Given this list of marker genes GNPDA2, PITX2, NAP1L3 (NCBI Gene Id 4675), CEACAM21, AP1S3, WAC, STEAP2, ZDHHC20, CCL2, MND1 (meiotic nuclear divisions 1), ENPP5, TRIM44, GSDME, ATP6V1B2, SH3KBP1 (SH3 domain containing kinase binding protein 1), AKAP17A, ACO1, WLS, RPGR, SRRM2, ZNF780A, MYO5A, LYSMD2, CCT3 (chaperonin containing TCP1 subunit 3), GPRIN3, TSR2, CPSF6, CMBL, BRD8, SLC20A1, ARRDC3, DISP1, MYOCD, PRTG, MARK1, ZNF454, C3AR1, GK, MAPRE2, CHD8, PAK5, SYAP1, TCAF1, LIG3 (NCBI Gene Id 3980), SLCO1A2, STRBP, NR2C2, SETD5, PDK1, LYN, RNF130 (ring finger protein 130), P4HTM, RIF1, CCN1, THOC1, SNHG14, PITRM1, ZNF467, ANKRD29, ID2, MOSPD2, CRYAA, ERICH3, HOXA10, NIPAL1, TRIM9, GMDS, CSGALNACT1, GLB1L, KMT5A, HDAC2, SLC43A3, C1QL3 (complement C1q like 3), ANKRD28, ANK3, EBF1, EID2, OLIG2, ADGRL4, MNDA, RTP4, SMOC2, PRELID2, HLA-B, MATR3, MAU2, THBS2, EMC9, MAPDA, SPDYA, FLT1, WDR33, USP14, ZNF286A, YES1, PLXNA2, EN1, SCRG1, NR3C1, ZMYM2, GATA6, KDM5C, SLBP, GLA, EGR1, SBSPON, DNAJA4, TTC9, CCDC103, ARSJ, RPL15, NCAM1, GDA, KAT7, DYNLT3, CFAP91, KIF24, MAOA, ST3GAL6, QNG1, PDE8A, TGM2, NID1, WDR37, BTBD7, DTNA, S1PR3, WASL, ZNF22, GOT2, MANBA, RP2, PCSK6, PLPP3, P3H2, SORD (sorbitol dehydrogenase), CENPE (centromere protein E), GALNS, FJX1, CNRIP1, JMJD1C, IGFBP7, TNFAIP2, HTRA1, HOXA7, MBTPS2, ARHGAP32, YTHDC2, C12orf42, PACC1, CLSTN1, TUBB2B, VEGFD, PLGRKT, CCL7, CXCL12, JAM2, NAV3, C2CD3, B3GAT1, TRIM2, ANKRD50, ATP7A, RMDN1, SBNO2 (NCBI Gene Id 22904), RGS2, SSX2IP, HUWE1, MYH9, TNFAIP8 (NCBI Gene Id 25816), ZNF518A, CAMK1D, PCDH19, TNRC6A, GJB2, CA5B, WIPF1, AKR1B10, NRP1, TPGS2, SYT12, EMP2, PPM1H, TDRKH, CRYL1, FHDC1, GAS2L3, HBEGF, RBMX, TP53 (tumor protein p53, NCBI Gene Id 7157), LHX9, CD209, APC, RNF138, PFKFB2, PRPF3, DTL, here is a description of the gene set: Up-regulated genes from the set A (Fig. 5a): specific to cells expressing MLL-AF4 fusion protein alone. from publication Gaussmann A, Wenger T, Eberle I, Bursen A, Bracharz S, Herr I, Dingermann T, Marschalek R (PMID 17130830) The reciprocal chromosomal translocation t(4;11) is correlated with infant, childhood, adult and therapy-related high-risk acute leukemia. Here, we investigated the biological effects of MLL.AF4, AF4.MLL or the combination of both reciprocal fusion proteins in a conditional in vitro cell culture model system. Several parameters like cell growth, cell cycling capacity, apoptotic behavior and growth transformation were investigated under physiological and stress conditions. Co-transfected cells displayed the highest resistance against apoptotic triggers, cell cycling capacity and loss-of-contact inhibition. These analyses were complemented by gene expression profiling experiments and specific gene signatures were established for each of the three cell lines. Interestingly, co-transfected cells strongly upregulate the homeobox gene Nanog. In combination with Oct4, the Nanog homeoprotein is steering maintenance of pluripotency and self-renewal in embryonic stem cells. Transcription of Nanog and other stem cell factors, like Oct4 and Bmi1, was verified in biopsy material of t(4;11) patient cells which express both reciprocal t(4;11) fusion genes. In conclusion, the presence of both reciprocal MLL fusion proteins confers biological properties known from t(4;11) leukemia, suggesting that each of the two fusion proteins contribute specific properties and, in combination, also synergistic effects to the leukemic phenotype. Human Gene Set: GAUSSMANN_MLL_AF4_FUSION_TARGETS_A_UP species: Mus musculus